The following is a description of a gene set: species: Homo sapiens from publication Zaslavsky E, Hershberg U, Seto J, Pham AM, Marquez S, Duke JL, Wetmur JG, Tenoever BR, Sealfon SC, Kleinstein SH (PMID 20164420) The dendritic cell (DC) is a master regulator of immune responses. Pathogenic viruses subvert normal immune function in DCs through the expression of immune antagonists. Understanding how these antagonists interact with the host immune system requires knowledge of the underlying genetic regulatory network that operates during an uninhibited antiviral response. In order to isolate and identify this network, we studied DCs infected with Newcastle Disease Virus (NDV), which is able to stimulate innate immunity and DC maturation through activation of RIG-I signaling, but lacks the ability to evade the human interferon response. To analyze this experimental model, we developed a new approach integrating genome-wide expression kinetics and time-dependent promoter analysis. We found that the genetic program underlying the antiviral cell state transition during the first 18-hours post-infection could be explained by a single regulatory network. Gene expression changes were driven by a step-wise multi-factor cascading control mechanism, where the specific transcription factors controlling expression changed over time. Within this network, most individual genes are regulated by multiple factors, indicating robustness against virus-encoded immune evasion genes. In addition to effectively recapitulating current biological knowledge, we predicted, and validated experimentally, antiviral roles for several novel transcription factors. More generally, our results show how a genetic program can be temporally controlled through a single regulatory network to achieve the large-scale genetic reprogramming characteristic of cell state transitions. Genes up-regulated in comparison of control conventional dendritic cells (cDC) at 0 h versus cDCs infected with Newcastle disease virus (NDV) at 12 h. Human Gene Set: GSE18791_CTRL_VS_NEWCASTLE_VIRUS_DC_12H_UP, and this is the list of marker genes: ZBTB8A, KLF3, FKBP14, ASL, TUBGCP5, TATDN2, ORC5, TUBA4A, PRADC1 (protease associated domain containing 1), PPP1R13B, TRMT1, SLC25A38, DCAF4, PAQR3, VBP1, TEFM, WDR3, DNAJC11, TERF1, PDCD6, PPP1R14B, BCS1L, HS3ST1 (NCBI Gene Id 9957), GSPT2, SUV39H2, YLPM1, POLR3B, PCYOX1, ELP6, SAMD13, CFAP251, ASTE1, ETV5, CFAP20, SKA2, GPATCH1, SLC26A2, PRMT5, TRAPPC13, EIPR1, GEMIN6, IL21R, TTLL1, AP2A2, TCHP, ZCCHC24, TM6SF1, MED29, KBTBD7, WNT5B, TTI2, COQ9, CDC123, BYSL, POLG2, METTL18, POLR3H, CCT6A, CRNKL1, ERP27, NUDCD2, CAD, NLRP2, ARB2A, MRTO4, PLPP6, ZNF542P, TEX264, NAXD, NSFL1C, NUP35, MBLAC2, FIGNL1, PTCD2, DCAF13, FLVCR1 (FLVCR choline and heme transporter 1), UMPS, IL16, TMEM273, ZNF180, MRPS26, BRAT1, B3GALNT1, SNX4, DDX28, MTX3, PRCP, TUBB6, SURF6, PPAT, SMIM15, VASH1, GNPDA2, STXBP5, EEF1AKMT2, NUDT6, RPAP2, FLVCR2, PKNOX1, TSC1, RTN4IP1, FAM98A, NOL11, MRPL4 (mitochondrial ribosomal protein L4), RHNO1, FAM204A, MRPS23 (mitochondrial ribosomal protein S23), TARDBP, C9orf40, MLYCD, SHPRH, RIPOR1, NCAPH, METTL25, WDR53, UCK2, MMS19, EXO5, MTIF3, FAM78A, NAPEPLD, TNRC18, DDIAS (DNA damage induced apoptosis suppressor), ANAPC15, TP53RK, PRPS1, INTS8, PNPLA6, RCAN3, COG2, IVD, HNMT, RLIG1, ZFP3, ZNF319, MRPL19, SS18L1, NAA15, TXNL4A, THAP11, PDIK1L, SRSF8, MDM1 (Mdm1 nuclear protein), CIAPIN1, DHX30, STRAP, MRPL15 (NCBI Gene Id 65001), USP46 (ubiquitin specific peptidase 46), IRF5, TPRG1L, NOL9, LRR1, HENMT1 (NCBI Gene Id 113802), RIPK4, NAPG (NSF attachment protein gamma), CDK4, TFB2M, TFAM (NCBI Gene Id 8033), ZNF227, ENDOG, SERAC1, BRMS1L, SIKE1, GTF3C2 (NCBI Gene Id 2976), UTP25, ATPSCKMT, IMPA2, TRPV2, CTR9, PIP4K2B, HLCS, TMEM185A, STAB1, SPRED1, PIK3R1, PHAX, ZNF35, NVL, DENND10, FLVCR1-DT, ZCCHC17, NFATC3, PWP2, PRDM15, HLTF, AKR1A1, CEP164, RAD51C, MTFR2, P2RY13 (NCBI Gene Id 53829), AKTIP, SNRPD1, RIC8A, MSH2, TMCO3, UTP14A, ULK3, STAM2, GATC